Given this list of marker genes Atf3, Ptpn18, Eef2, Klf2, Tsc22d3, H2-Ab1, Nsa2, Abca9, Eif3f, Cd47, Xist, Emb, Tmem176b, Hexb, Bnip3l, Cd81, Ppp1r15a, H2-Eb1, Itm2b, Tifa, Rgs2, Man2b1, Lyst (NCBI Gene Id 217998), Bri3, Gpx4, Lsp1, Junb, Ier2, Zeb2, Rnase6, Il6ra, Creg1 (NCBI Gene Id 433375), Fau, Klhl24, Trps1, Ms4a6c, Foxp1, Npc2, Slc43a2, Pid1, Hfe, Cd180, Aph1c, Sult1a1, Ramp1, C3, Gns, Irf8, Adgre1, Arl5c, Cybb, Btg2, Otulinl, Ctsh, Arl4c (ADP-ribosylation factor-like 4C), Ccl9 (NCBI Gene Id 20308), H2-D1, Erp29, Fuca1, Ighm, Itga4, Ifngr1, Dusp1, Ucp2, Prcp, Calhm6, Cx3cr1 (NCBI Gene Id 13051), Surf1, Tent5a, H3f3a, Pirb (paired Ig-like receptor B), Sirpa, Zfp36, Sat1, Cd300c2, Grn, Alox5ap (NCBI Gene Id 11690), Neat1, Mxd4, Slc44a1, Ctss, Tpd52, Ifitm2, Fos, Ptprc, H2-Aa, Nfkbiz, Marveld1, H2az1 (NCBI Gene Id 51788), Tmem176a, Pold4, Lztfl1, Pmaip1, Lyz2, Il6st, Tyrobp, Gmfg, Cox7a2l, Fosb, Ypel3, Klf4, here is a description of the gene set: Cytokines mediate cell-cell communication in the immune system and represent important therapeutic targets. A myriad of studies have highlighted their central role in immune function, yet we lack a global view of the cellular responses of each immune cell type to each cytokine. To address this gap, the authors created the Immune Dictionary, a compendium of single-cell transcriptomic profiles of more than 17 immune cell types in response to each of 86 cytokines (>1,400 cytokine-cell type combinations) in mouse lymph nodes in vivo. A cytokine-centric view of the dictionary revealed that most cytokines induce highly cell-type-specific responses. For example, the inflammatory cytokine interleukin-1β induces distinct gene programmes in almost every cell type. A cell-type-centric view of the dictionary identified more than 66 cytokine-driven cellular polarization states across immune cell types, including previously uncharacterized states such as an interleukin-18-induced polyfunctional natural killer cell state. from publication Cui A, Huang T, Li S, Ma A, Pérez JL, Sander C, Keskin DB, Wu CJ, Fraenkel E, Hacohen N (PMID 38057668) species: Mus musculus Genes negatively differentially expressed in cell type: cDC2 (conventional dendritic cell type 2) upon treatment with cytokine: GM-CSF in mouse lymph nodes in vivo. Mouse Gene Set: CUI_CDC2_GM_CSF_RESPONSE_DN